Given this list of marker genes Psap, Entrep3, Ctsd, Tcf7, Cyth4, Add1, Ankrd12, S100a11, Macf1, Klf6, Btg1, Il16, Tspan32, Neurl3, Dapl1, AI467606, Nsg2, Tspo, Cdkn1b, Elf1, Ypel3 (NCBI Gene Id 68930), Tdrp, Tmem50a, Trp53inp1, Rsrp1, Cd5, Peli1, Ipcef1, Pou2f2, Txnip, Luc7l2, Ostf1, Ets1, Lbh, Rflnb, Pik3r1, Lsp1, Gmfg, Lef1, Arhgap45, Tent5a (NCBI Gene Id 320335), Stim1, Sh3kbp1, Stk38, Jak1, Itga4 (integrin alpha 4), Sh2d1a, Tmem59, Ankrd44, Eef1a1, Pbxip1, Add3, Pnrc1, Scml4, Jakmip1, Smc4, Arhgap15, Hmgb2, Ighm, Ube2h, Rb1cc1, Zfp36l1, Kmt2e (lysine (K)-specific methyltransferase 2E), Prrc2b, Saraf (NCBI Gene Id 67887), Klf2, Clk1, Cxcr4, Sugt1, Pik3ip1, Scp2, Foxo1, Plec, Pdcd4, Adgre5, Arhgef18, Hp1bp3, Tsc22d3, Pglyrp1, AB124611, Sell, Evl, Malt1, Hcst, Eif3f, Mgst2, Myh9, Ahnak, Tnrc6b, Limd2, Cd3d, Zbtb20, Akap13, 9930111J21Rik2, Srgn, Slc12a7, Sidt1, Tcp11l2, Cd8b1, Cd55, Ccr9, Fos, Arhgef1, Gm2a, Nop53, Il18r1, Ndufa6, Chd3, Gpr174, Klhl24, Selenop, Esyt2, Acp5, Klf3 (Kruppel-like transcription factor 3 (basic)), Stk4 (serine/threonine kinase 4), Rasgrp2, Gpx4, H2az2, Map4k4, Dguok, Arhgdib, Bnip3l, Neat1, Ifngr1, Crip1, Grap2 (NCBI Gene Id 17444), Hdac7, Fyb1, Cmah, Kif21b, Satb1, Pycard, Rgs2, Gimap6, Rnf167, Mxd4, Arl5c, Ccl5, Gigyf1, Srpk2, Ripor2, Cd28, Selplg, Pold4, Kdm7a, Actn1, Slamf6, Smad7, Cd37, Tecpr1, Pcmtd1, Bin2, Themis, Ift80, Fam78a, Gtf2i (general transcription factor II I), Atp1b3, Gnai2, Cox7a2l, Smap2, Nsa2, Cd7, Cirbp, S100a10, Smpdl3a, Myl12b, Utrn, Klrd1, Tmem71 (transmembrane protein 71), Adcy7, Emp3, Uba52, Gramd1a, Cd3g, Ldlrap1, Itm2b, Npc2, Zfp36l2, Il7r, Ptpn22, Supt4a, S1pr1, Madd (NCBI Gene Id 353087, MAP-kinase activating death domain), Phf20l1, Ucp2, Paip2, Eef2, Pfdn5, Crlf3, Rgs10, Btg2, Dap, here is a description of the gene set: Cytokines mediate cell-cell communication in the immune system and represent important therapeutic targets. A myriad of studies have highlighted their central role in immune function, yet we lack a global view of the cellular responses of each immune cell type to each cytokine. To address this gap, the authors created the Immune Dictionary, a compendium of single-cell transcriptomic profiles of more than 17 immune cell types in response to each of 86 cytokines (>1,400 cytokine-cell type combinations) in mouse lymph nodes in vivo. A cytokine-centric view of the dictionary revealed that most cytokines induce highly cell-type-specific responses. For example, the inflammatory cytokine interleukin-1β induces distinct gene programmes in almost every cell type. A cell-type-centric view of the dictionary identified more than 66 cytokine-driven cellular polarization states across immune cell types, including previously uncharacterized states such as an interleukin-18-induced polyfunctional natural killer cell state. studied in species Mus musculus Mouse Gene Set: CUI_T_CELL_CD8_IL15_RESPONSE_DN from publication Cui A, Huang T, Li S, Ma A, Pérez JL, Sander C, Keskin DB, Wu CJ, Fraenkel E, Hacohen N (PMID 38057668) Genes negatively differentially expressed in cell type: CD8+ T cell upon treatment with cytokine: IL-15 in mouse lymph nodes in vivo.